Given this list of marker genes TAS1R1, GNAT3, GNAT1, RGS21, CALHM1 (calcium homeostasis modulator 1), TAS1R3, ITPR3, here is a description of the gene set: Human Gene Set: GOBP_SENSORY_PERCEPTION_OF_UMAMI_TASTE The series of events required to receive an umami taste stimulus, convert it to a molecular signal, and recognize and characterize the signal. Umami taste is the savory taste of meats and other foods that are rich in glutamates. This is a neurological process. species: Homo sapiens